Given this list of marker genes Gys1, Ppp1r3c, Pgm1, Gbe1, Gyg1 (NCBI Gene Id 99787), Ugp2, here is a description of the gene set: Glycogen synthesis Mouse Gene Set: REACTOME_GLYCOGEN_SYNTHESIS studied in species Mus musculus